Given this list of marker genes Piga, Pigh, Pyurf, Dpm2, Pigc, Pigyl, Pigp, Pigq, here is a description of the gene set: Mouse Gene Set: GOCC_GLYCOSYLPHOSPHATIDYLINOSITOL_N_ACETYLGLUCOSAMINYLTRANSFERASE_GPI_GNT_COMPLEX An enzyme complex that catalyzes the transfer of GlcNAc from UDP-GlcNAc to an acceptor phosphatidylinositol, the first step in the production of GPI anchors for cell surface proteins. The complex contains PIG-A, PIG-C, PIG-H, PIG-Q, PIG-P, and DPM2 in human, and Eri1p, Gpi1p, Gpi2p, Gpi15p, Gpi19p, and Spt14p in budding yeast. studied in species Mus musculus